The following is a description of a gene set: Human Gene Set: MORF_KDR Neighborhood of KDR kinase insert domain receptor (a type III receptor tyrosine kinase) in the MORF expression compendium Neighborhood of KDR studied in species Homo sapiens, and this is the list of marker genes: IL11RA, MLLT10, DMD, SLC22A6, FSHR, NTRK3, CCL16, SUPT3H, TMEM26, JRKL, ZSCAN26, FAS, ABCB10, ABCC8, H3C6, ITIH3, KRT2, MYL3, ADAMTSL3, ATXN3, TBX19 (NCBI Gene Id 9095), COL14A1, SLC6A2, RXRG, ERCC4, GJB5, EPHB2, PVR, PTPRB, KDR, PGM3, P2RY10, OCM, PHLDB1, POLR1HASP, HNF1A, NR3C2, ASB4, KNG1, AOC4P, RREB1, FBXL4, SPA17, KRT34, SGPL1, EDIL3, TSSK2, CAMK4, DBT, COL8A1 (NCBI Gene Id 57086), AQP7, S100A5, COX6A2, MC5R, BMP10, GUCY2F, NPFF, CYP2E1, SGCD (NCBI Gene Id 6444), VSTM4, RAD51D, CD8A, FZD5, SIM2, COLGALT2, PLA2R1, CXCL5, NR1I2, F2RL3, AMOT, ACKR1, ARL3, PHOX2B, ERC2-IT1, NTNG2, CDC73, CADM4, LGI1, IL16, MAGEA9, SLC4A8, PCDHGB7, OPLAH, PSG1, GPR171, EXOC6B, COL19A1, IGKV7-3, PART1, POU6F1 (NCBI Gene Id 5463), ZNF266, ABO, FGF18, SERPINA4